The following is a description of a gene set: studied in species Mus musculus electronically inferred by orthology from the curated human pathway part of: Post-translational modification: synthesis of GPI-anchored proteins Reactome Pathway: Synthesis of glycosylphosphatidylinositol (GPI) This event has been computationally inferred from an event that has been demonstrated in another species.<p>The inference is based on the homology mapping from PANTHER. Briefly, reactions for which all involved PhysicalEntities (in input, output and catalyst) have a mapped orthologue/paralogue (for complexes at least 75% of components must have a mapping) are inferred to the other species., and this is the list of marker genes: Pigl, Pigyl, Pigz, Pigg, Pigv, Piga, Pigx (NCBI Gene Id 72084), Pigp, Pigw, Pigf, Pigb (NCBI Gene Id 55981)